Given this list of marker genes Snx5, Erfe, Appl2, Mfn2, Cul3, Pid1, Ptpn11, C1qtnf9, Uso1, Pip4k2b, Osbpl8, Nr1h4, Adipor1, Zfp592, Kank1, Sco1, Ncoa1, Enpp1, Pak1, Pip4k2a (phosphatidylinositol-5-phosphate 4-kinase, type II, alpha), Bglap (NCBI Gene Id 12096), Kbtbd2, Bglap3, Fbxw8, Src, Grb10, Ncl, Myo5a, Zbtb7b, Rbx1, Socs1, Tsc2, Prkca, Il1b, Tns2, Gkap1 (NCBI Gene Id 80584), Grb14, Echdc3, Ptprf, Nucks1, Prkaa1, Marcks, Grb7, Ankrd26, Opa1, Myo1c, Socs3, Pparg, Ins2, Ptpre, Slc27a4, Lep, Pip4k2c, Ahsg, Lonp1, Ptpn2, Gsk3a, Mstn (myostatin), Sorl1, Ptpn1, Inpp5k, Ncoa5, Prkcz, Ncoa2, Rps6kb2, Prkcb, Prkcq, Rela, Nck1, Sirt1, Trim72, Blvrb, Tnf, Gsk3b, Grk2, Esrra, Bglap2, C1qtnf12, Mir143, Sorbs1, Ctsd, Gnai2, Nucb2, Ide, Atp2b1, Inppl1, Gpr21, Cul7, Prkcd, Irs1, Ins1, Agt, Gpld1, Lpl, Ptprj, Rps6kb1, Igf2, Serpina12, here is a description of the gene set: Any process that modulates the frequency, rate or extent of cellular response to insulin stimulus. Mouse Gene Set: GOBP_REGULATION_OF_CELLULAR_RESPONSE_TO_INSULIN_STIMULUS studied in species Mus musculus